The following is a description of a gene set: species: Homo sapiens part of: FGFR1 mutant receptor activation Reactome Pathway: Signaling by FGFR1 amplification mutants Amplification or activation of FGFR1 has been reported in lung cancer, breast cancer, oral squamous carcinoma, esophageal squamous cell carcinomas, ovarian cancer, bladder cancer, prostate cancer and rhabodomyosarcoma. Unlike the case for FGFR2 amplifications, FGFR1 amplifications are not associated with additional point mutations and affect signaling without altering the intrinsic kinase activity of the receptor. Overexpressed FGFR1 appears to signal at a basal level in a ligand-independent fashion, but is also able to be stimulated by exogenous ligand. Downstream activation may be the result of aberrant paracrine or autocrine stimulation. FGFR1 amplification has not been conclusively demonstrated to be the causative oncogenic agent in all of the cancer types mentioned above, and other genes in the 8p11 region may also be candidates in some cases., and this is the list of marker genes: FGFR1